The following is a description of a gene set: Mouse Gene Set: GOBP_REGULATION_OF_EPITHELIAL_CELL_DIFFERENTIATION_INVOLVED_IN_KIDNEY_DEVELOPMENT species: Mus musculus Any process that modulates the frequency, rate or extent of epithelial cell differentiation involved in kidney development., and this is the list of marker genes: Wwtr1, Prkx, Stat1, Osr1, Fat4, Wnt9b, Lif, Ctnnb1, Mmp9, Yap1, Prom1, Cited1, Pax8, Gdnf, Lhx1, Pax2 (paired box 2), Gata3, Sall1, Cd24a